The following is a description of a gene set: Human Gene Set: SILIGAN_TARGETS_OF_EWS_FLI1_FUSION_UP species: Homo sapiens In all, 85% of Ewing's sarcoma family tumors (ESFT), a neoplasm of unknown histogenesis, express EWS-FLI1 transcription factor gene fusions. To characterize direct target genes avoiding artificial model systems, we cloned genomic DNA from ESFT chromatin precipitating with EWS-FLI1. We now present a comprehensive list of 99 putative transcription factor targets identified, for the first time, by a hypothesis-free approach based on physical interaction. Gene-derived chromatin fragments co-precipitating with EWS-FLI1 were nonrandomly distributed over the human genome and localized predominantly to the upstream region and the first two introns of the genes. At least 20% of putative direct EWS-FLI1 targets were neural genes. One-third of genes recovered showed a significant ESFT-specific expression pattern and were found to be altered upon RNAi-mediated knockdown of EWS-FLI1. Among them, MK-STYX, encoding a MAP kinase phosphatase-like protein, was consistently expressed in ESFT. EWS-FLI1 was found to drive MK-STYX expression by binding to a single ETS binding motif within the first gene intron. MK-STYX serves as precedence for successful recovery of direct EWS-FLI1 targets from the authentic ESFT cellular context, the most relevant system to study oncogenic mechanisms for the discovery of new therapeutic targets in this disease. Genes bound by EWSR1-FLT1 fusion and up-regulated in STA-ET-7.2 cells (Ewing's sarcoma) after knockdown of EWSR1-FLT1 by RNAi. from publication Siligan C, Ban J, Bachmaier R, Spahn L, Kreppel M, Schaefer KL, Poremba C, Aryee DN, Kovar H (PMID 15735734), and this is the list of marker genes: VGF, MDH2, RHOBTB3, PCLO, KAZN, TCF12, CDK7, NPY, NCAM1, TAOK1, RIC1, LIPA, LIMS1, ATP1B1, NAA35